Given this list of marker genes HCN4, ANK2, CACNA1D, SCN5A, CACNA1G, here is a description of the gene set: Human Gene Set: GOBP_MEMBRANE_DEPOLARIZATION_DURING_SA_NODE_CELL_ACTION_POTENTIAL The process in which SA node cardiac muscle cell membrane potential changes in the depolarizing direction from the negative resting potential towards the positive membrane potential that will be the peak of the action potential. studied in species Homo sapiens